Given this list of marker genes TTPA, PPFIBP2, TCN2, MYOZ1, CX3CL1, USP29, CFAP97D1, COX6A2, HLA-DOA, PRKN, GNRHR, FIS1, FTMT, DPYSL5, BIRC3, PIWIL4, ANGEL1, TNFRSF12A, RPS27, KLHL25, ARHGAP18, CISH, BPIFB3, MCAT, FNDC10, NR3C2, SLC26A6, SERINC4, METTL21A, SERPINB1, TNFRSF18, ITM2B, DCLK2, XKR4, SNX33, TPRG1L, MED7, LRP2BP, TMEM108, RHEBL1, RPL39, ADAT1, FAM83H, VIPR1 (NCBI Gene Id 9357), SMURF2, ZBTB7C, BMP1, GM2A, NRROS, OTX1, OTULINL, FGL1, DAND5, SLC16A7, LAMB3, CZIB, CCR5, LRRC66, SULT1A1, HSD17B11, PAPPA2, GIMAP8, DENND6A, ACADSB, TMEM270, ELMOD3, CIB4, PRPF40B, MEIS1, CYP11B1, OSBPL5, CCPG1, PRCD, SPACA9, RABAC1, RNASET2, BCO2, RPL38, CFAP70 (cilia and flagella associated protein 70), FAM89A, GLIPR1L1, NOP10 (NOP10 ribonucleoprotein), SARM1, HPS3, IFFO2, NR1D2, ITPK1, TRNAU1AP, KCTD14, SDS, CIAO3, TTLL10 (NCBI Gene Id 254173), CCN1, CACNA1C, S1PR4, RTP4, AK4, WDR53, MAP4K3, ZCCHC13, B3GNT5, VKORC1, GPR4, NCF4, FAM43A, TBC1D17, B3GNT8, LDHD, ATP1B1, FILIP1L, NFKBIZ, SCN2A, FAM219B, MTCL1, HEXA, WWC1, JPH4, C12orf75, MRGPRG, LPCAT2, ASB6, MYRF, GPR65, RNASE6, GSTK1, STXBP3, RDH16, RIGI (NCBI Gene Id 23586), ARMC3, DIPK1A, C1orf56, MYLK4, TLR2, GPR174, EDF1, OMP, RPS15A, RASAL2, SLFN5, SHF, PLXNA4, ITGB7, MCF2, SLC19A1, CHRD, EVI2A, CREB3, CAPG, ZMYND11, TSC22D3, PXYLP1, ESYT1, NRP2 (NCBI Gene Id 8828), CRB3, CIB2, HEXB, GPX4, PDE1A, HLA-C, SPRY3, ESRRG, STX8, STYK1, ALKBH7, ABCA1, MRPS24, MDGA2, FADS6, ABHD12, IGKC, CCRL2, LTB, SPRY1, HES1, BET1L, MACIR, RPUSD3, EMP3, PRELID2, NECTIN4, IL10RB, NDUFB9, RPL13A, TRIM3, MORC3, NLRP10, CD38, TSPO2, ST6GALNAC1, LY86, C2orf76, CDH26, NEU2, C12orf57, CGAS, ROMO1, CCDC28A, SLC35D2, MRPL23, BRDT, here is a description of the gene set: studied in species Homo sapiens Type I and type II interferons (IFNs) bind to different cell surface receptors but activate overlapping signal transduction pathways. We examined the effects of a type I IFN (IFN-acon1) and a type II iFN (IFN-g1b) on gene experession in A549 cells and demonstrate that there is a common set of genes modulated by both IFNs as well as a set of gene specifically regulated by each, reflecting the activation of different signaling pathways. In particualr, IFN-g induced many more genes of the signaling pathways, apoptosis, and cytokine interactions than did IFN-a. Even with genes induced by both IFNs there were distinctive quantitativive differences in expression. IFN-g1b plays a major role in the induction and regulation of the complement pathway. Previous work has shown a synergistic antivral and antiproliferative effect of type I and type II IFNs in cell culture and in the treament of tumors in mice. We demonstrate that a majority of genes showed and additive effect of IFN-acon1 and IFN-g1b, but a subset of gene is synergistically induced; these incluce ISG10, MX2, OAS2, and other genes known to be involved in the antiviral response, TRAIL (TNFSF10) and caspases involved in apoptosis and chemokine genes RANTES, CXCL10, and CXCL11. Greater than additive transcription of some of these genes in the presence of both IFNs was confirmed by real-time kinetic RT-PCR. Elevated induction of many of these genes may be sufficient to explain the synergistic antiviral and antitumor effects of this combination of IFNS in vivo. Genes down-regulated in epithelial cells (24h): IFNG versus interferon alpha. from publication Sanda C, Weitzel P, Tsukahara T, Schaley J, Edenberg HJ, Stephens MA, McClintick JN, Blatt LM, Li L, Brodsky L, Taylor MW (PMID 16800785) Human Gene Set: GSE5542_IFNG_VS_IFNA_TREATED_EPITHELIAL_CELLS_24H_DN